The following is a description of a gene set: Human Gene Set: GSE22432_MULTIPOTENT_PROGENITOR_VS_PDC_UP studied in species Homo sapiens Genes up-regulated in dendritic cells: amplified common progenitors versus plasmacytoid. from publication Felker P, Seré K, Lin Q, Becker C, Hristov M, Hieronymus T, Zenke M (PMID 20881193) Dendritic cells (DCs) in lymphoid tissue comprise conventional DCs (cDCs) and plasmacytoid DCs (pDCs) that develop from common DC progenitors (CDPs). CDPs are Flt3+c-kitintM-CSFR+ and reside in bone marrow. Here we describe a two-step culture system that recapitulates DC development from c-kithiFlt3-/lo multipotent progenitors (MPPs) into CDPs and further into cDC and pDC subsets. MPPs and CDPs are amplified in vitro with Flt3 ligand, stem cell factor, hyper-IL-6 and insulin- like growth factor-1. The four-factor cocktail readily induces self-renewal of MPPs and their progression into CDPs and has no self-renewal activity on CDPs. The amplified CDPs respond to all known DC poietins and generate all lymphoid tissue DCs in vivo and in vitro. Additionally, in vitro CDPs recapitulate the cell surface marker and gene expression profile of in vivo CDPs and possess a DC-primed transcription profile. Transforming growth factor-β1 (TGF-β1) impacts on CDPs and directs their differentiation towards cDCs. Genome-wide gene expression profiling of TGF-β1-induced genes identified transcription factors, such as interferon regulatory factor-4 (IRF-4) and RelB, that are implicated as instructive factors for cDC subset specification. TGF-β1 also induced the transcription factor inhibitor of differentiation/DNA binding 2 (Id2) that suppresses pDC development. Thus, TGF-β1 directs CDP differentiation into cDC by inducing both cDC instructive factors and pDC inhibitory factors., and this is the list of marker genes: TMEM202, SDHAF2, AGXT2, HTR2B, PANK2, NR1H2, RNF115, SLC6A12, TAP1, HLA-E, RTP4, PPP2R1A, TRIM7, NMT1, AKIRIN2, UBE2R2, STX18, TRAF2, SLC8B1, PER1, IL17RB, XAB2 (XPA binding protein 2), C6orf136, HAND1, UBTD1, TRAFD1, ZNF18, CLN8 (CLN8 transmembrane ER and ERGIC protein), PPP2R2A, GOLGA3, WNT3A, MTARC2, GBP4, ASAH2, MOCS2, THBS4, DOK3, PPP2R3C, AFG3L2, PLAC8, EAPP (NCBI Gene Id 94452), LEMD2, KHNYN, ZNF688, HMOX1, TBC1D10C, NUB1, FBXO32, DNAL1, RABEP2, TRIM41, CEP95, DNAH2, MED10, THAP4, PRG4, GTPBP2, RNF181, IFT22, TMEM120A, TSTD2, LETMD1, PLBD2, LY86, MRPS18A, ABI3, NCF4, DCAF15, P2RX2, PARP8, IL2RA, POLR3C, TOM1L2, SLAMF8, FAM241A, GPR15, CEBPB, C5, CRB1, SEPTIN4, LRRC3, PPP1R11, KDM4B (lysine demethylase 4B), PTMS, C10orf120, IFIH1, ONECUT3, MAVS, TOX, NSUN4, STXBP1, DXO, CRIPT, GOLPH3L, PPCDC, ZC2HC1A, DCAF10, AGO2, NPEPPS, STK40, ATP2B3, NBDY, FAM174A, SCX, DAPK3, B2M (beta-2-microglobulin), NUDT9, RAB11A (NCBI Gene Id 8766), CST7, REEP6, DNMT3A, NOS2 (nitric oxide synthase 2), RAB10 (NCBI Gene Id 51140), RAB29, GLRX, PLA1A, MIP, CHIC1, SCNN1B, BCL7B, MOV10 (Mov10 RNA helicase), IFT172, RSAD2, ACP2, CDK5RAP2, CMPK2, ZNF264, TMCO3, GLIPR2, TRIT1, ARID5B, NUMBL, NUDT18, ZUP1, MON1A, ADAM7, RPS6KB2, GAB2, FBXL12, MX2, WFIKKN2, NUDT13, SERPINB8 (NCBI Gene Id 5271), RGS1, GBX2, AP3S1, DCLRE1C, UCKL1, HLA-G, ANKLE2, XKR8, PTTG1, CXCR5, ADIPOR1, EXOC6, M1AP, FANCA, RASA4, ATG2A, CCND2, MERTK, CXXC4, NAGPA, SPINK4, TOR3A, DENND1A, SUPT4H1, SPO11, TCERG1L, DUSP10, ENDOD1, PRPF38A, VPS11, CRYGB, POLD3, STAT1, MARCHF10, HTRA2, FXYD6, TNFRSF9 (NCBI Gene Id 3604), TFEB (transcription factor EB), DYNC1I2, LY6E, HLA-DOA, CREBL2, FBXO7, TEN1, TDRD7, TSC22D4 (NCBI Gene Id 94778), PIAS1, CYTH2, TEX9, MRPL4, RRBP1, ZC3H6, IFIT1B, ACSL1, ARL4A, TREML2, GIPC1